Given this list of marker genes PIP4K2C, F10, TLCD4, SHE, CD93, MED1, CAVIN1, MEA1, PSME1, BRK1, SLC39A8, SLC4A1, RAMP2, KPNA1, REEP6, ARL6IP5, SAR1B, DCTPP1, BMP2K, HBA2, TFPI, FXN, ADAM19, JKAMP, LPL, BCL6B (BCL6B transcription repressor), ELL2, SOX18, FLT4, NET1, GSTK1, TOM1L1, EPB42, IGF1, HBB, RNF149, MBP, GSTM1, TMED4 (transmembrane p24 trafficking protein 4), GATA1, DAXX, RHAG, PTTG1, KLF1 (NCBI Gene Id 8055), ACTB, KIFC1, ANGPT2, SMIM1, GFI1B, IFITM3, ACTC1, LMNB1, RALY, CSNK2A1, FMO1, ENG, MRPL58, LIG1, GDAP2 (ganglioside induced differentiation associated protein 2), H19, POLR2J, CREG1, STAB1 (NCBI Gene Id 23166), C17orf49, NFATC1, ACP1, CLDN5, here is a description of the gene set: The first hematopoietic and endothelial progenitors are derived from a common embryonic precursor termed the hemangioblast. The genetic cascades that regulate the differentiation of the hemangioblast to hematopoietic and endothelial cells are largely unknown. In general, much of embryonic development is coordinately regulated by temporal and spatial expression of transcription factors, such as the Homeobox (Hox) gene family. We and others isolated a divergent homeobox gene termed Hex (or Prh) that is preferentially expressed in hematopoietic and endothelial cells. Using in vitro Hex-/- embryonic stem (ES) cell differentiation, in vivo yolk sac hematopoietic progenitor assays, and chimeric mouse analysis, we found that Hex is required for differentiation of the hemangioblast to definitive embryonic hematopoietic progenitors and to a lesser extent endothelial cells. Therefore, Hex is a novel regulator of hemangioblast differentiation to hematopoietic and endothelial cells. studied in species Mus musculus Genes down-regulated in day 6 embryoid bodies derived from embryonic stem cells (ES) with HEX knockout. from publication Guo Y, Chan R, Ramsey H, Li W, Xie X, Shelley WC, Martinez-Barbera JP, Bort B, Zaret K, Yoder M, Hromas R (PMID 12791650) Human Gene Set: GUO_HEX_TARGETS_DN